Given this list of marker genes AKAP7, BTC, USP2, SPINK4, SLC25A25, NEURL4, REXO1, MSL2, AMACR, PHF1, ATP9A, CA2, APP, DNAJA2, TSSK2, MAPK8IP3, TIMP2, RAB17, SLC6A8, ZDHHC5, CRY2, ERCC2, CSF2, PKD1, LTBP1, TMEFF1, HAO2, NR2C1, PAPSS2, DLX1, FABP7, EIF4H, DDX41, TNF, MIP, CANT1, TRAK2, GGPS1, HYOU1, APC, AKIRIN1, ADORA1, SOWAHC, DDA1, CELA2A, MX1, METTL1, CEL, MYOM2, CDS2, NFIX, GZMA, STK40, SF3A2, LHCGR, HBEGF, TRAF2, ZKSCAN1, KLF4, MYL6, HOXA3, RASGRF2, INSM1, EEF1A2, RCVRN, GABRR2, PRPSAP2, TCEA2, TRIM13, PPFIBP2, STAT5A, ARID3B, TGIF2, APOBEC2, ADGRG3, KRT7, TGM2, RBM4B, ASGR2, SPSB1, SIAH1, RAE1, MAP3K3, POLG2, C19orf48P, ADRB2, MTFR1L, F9, LALBA, JMJD6, CYP3A43, N4BP1, CCDC152, PRDM5, CCK, SUMO2P7 (NCBI Gene Id 100131823), CCKBR, NFE2L1, RPS6KA2, RANBP10, PGK2, HSPA1B, GDAP2, POMC, LUC7L (NCBI Gene Id 57202), STRN4, SPR, GALNT10, BRWD3, HES2, RETREG2, TLR7, CFH, AGRN (NCBI Gene Id 389836), SLFN12, CNTRL, SLC25A51, SEC11C, DENND2B, HR, BSDC1, NCOA3, TULP3, SLC7A11, BPNT1, NRTN, CALR, NEDD4L, PCSK7, RAB33B, RRP9, SARS2, MAP1LC3A, SURF4, CCR9, DTX1, MYH7, CPXM2, TLX2 (T cell leukemia homeobox 2), RPL12, ABCG1 (ATP binding cassette subfamily G member 1), USP21 (ubiquitin specific peptidase 21), SLC30A1, TCF20, CLTB, COL6A2, ZPR1, IDH3A, MEOX2, GRIA3, FRAT1, NECAP1, BMP6, SH2B3, SPRYD7, ACVR2A, DNAJB4, CYB5R1, NQO1, RPL37A, HGF, KITLG, GREM2, ST7, DNAJC11, PRCC, PHRF1, ACTR1B, SGPL1, GBF1, POLR1A, UBE2E3, USF2, ALKBH5, F3, WDR43, SPPL2B, DVL1, SLC39A4, SOX4, POLR3D, TAF1A, E2F5, NDUFAF4, DUSP12, TFPI2, NR1D2, ALOX12, CTNNAL1, MAP4K3, SUB1, SLC22A1 (NCBI Gene Id 6580), PI4K2A, KLHL21, BMP2K, ADGRL1, TRIB3, FGD3, CD1D, NMU, here is a description of the gene set: Differentiation of naive CD8 T cells into cytotoxic effector cells requires three distinct signals- antigen (signal 1), costimulation -B7-1 (signal 2) and cytokine, either interleukin-12 or interferon-a/b (signal 3). Interaction of naive CD8 T cells with antigen and B7-1 programs cell division and proliferation whereas the presence of cytokines- IL-12 or IFNa/b promote survival, differentiation and memory establishment. In the absence of signal 3, the cells interacting with antigen/B7-1 undergo tolerance induction. The objective of this study was to elucidate the mechanisms how the provision of signal 3 promotes differentiation and averts tolerance induction in CD8 T cells. Trichostatin A is a pharmacological agent that inhibits histone deacetylase activity, hence regulating chromatin structure and gene expression and differentiation in many cell types. Gene signature profiles of IL-12, IFNa/b and trichostatin A stimulated cells were compared to elucidate the molecular mechanisms of gene regulation. Oligonucleotide microarray analysis is carried out to determine the extent and molecular nature of the CD8 T cell differentiation program induced by IL-12 or IFNa/b in concert with antigen and B7-1 signal. Genes up-regulated in comparison of CD8 T cells at 0 h versus those at 72 h. species: Homo sapiens from publication Agarwal P, Raghavan A, Nandiwada SL, Curtsinger JM, Bohjanen PR, Mueller DL, Mescher MF (PMID 19592655) Human Gene Set: GSE15930_NAIVE_VS_72H_IN_VITRO_STIM_CD8_TCELL_UP